Given this list of marker genes PPP1R3B, ASXL3, CD3D, LINC00242, CD3G, CSGALNACT1, KIAA2013, ITGB2, AIM2, here is a description of the gene set: Human Gene Set: FIGUEROA_AML_METHYLATION_CLUSTER_2_DN from publication Figueroa ME, Lugthart S, Li Y, Erpelinck-Verschueren C, Deng X, Christos PJ, Schifano E, Booth J, van Putten W, Skrabanek L, Campagne F, Mazumdar M, Greally JM, Valk PJ, Löwenberg B, Delwel R, Melnick A (PMID 20060365) We hypothesized that DNA methylation distributes into specific patterns in cancer cells, which reflect critical biological differences. We therefore examined the methylation profiles of 344 patients with acute myeloid leukemia (AML). Clustering of these patients by methylation data segregated patients into 16 groups. Five of these groups defined new AML subtypes that shared no other known feature. In addition, DNA methylation profiles segregated patients with CEBPA aberrations from other subtypes of leukemia, defined four epigenetically distinct forms of AML with NPM1 mutations, and showed that established AML1-ETO, CBFb-MYH11, and PML-RARA leukemia entities are associated with specific methylation profiles. We report a 15 gene methylation classifier predictive of overall survival in an independent patient cohort (p < 0.001, adjusted for known covariates). studied in species Homo sapiens Cluster 2 of aberrantly hypomethylated genes in blasts from AML (acute myeloid leukemia) patients.